Given this list of marker genes RARRES2, VIP, DEFA4, FAM3A, IL36RN, LTF, CAMP, APP, NPY, TAC1, ANG, CALCA, ADM, here is a description of the gene set: An immune response against a fungus mediated through a body fluid. An example of this process is the antifungal humoral response in Drosophila melanogaster. species: Homo sapiens Human Gene Set: GOBP_ANTIFUNGAL_HUMORAL_RESPONSE